Given this list of marker genes TRIP11, COL2A1, RNU4ATAC, RMRP, FN1, here is a description of the gene set: Biconvex vertebral bodies Human Gene Set: HP_BICONVEX_VERTEBRAL_BODIES Presence of abnormal convexity of the upper and lower end plates of the vertebrae, i.e., an exaggerated bulging out of the upper and lower vertebral end plates. studied in species Homo sapiens